Given this list of marker genes Mfn2, Insr, Rbm46, Cited2, Eif4g3, Ptafr, Syce3, Prss37, Unc5c, Ccr6, Lfng, Prdm9, Bnc1 (NCBI Gene Id 12173), Pla2g10, Oxtr, Src, Dhx37, Smurf2, Ube2b, Knl1, Ooep, Cfap69, Cftr, Tmprss12, Meiosin, Inhba, Bax, Fam170b, Adam7, P2ry1 (purinergic receptor P2Y, G-protein coupled 1), Cdc25b, Lhfpl2, Sry, Hdac2, Irgc, Rnase10, Tacr3, Plcb1, Sox9, Zp3, Dazl, Eif2s3y, Tacr1, Ctnnb1, Mapk15, Wt1, Wnt4, Ednrb (NCBI Gene Id 13618), Tac4, Sema3a, Prdm14, Rad51ap1, Cdc25c, Ago2, Plb1, Cib1, Sirt2, Syde1, Cdc25a, Npm2, Npr2, Msx1, Msx2, Cacna1h, Inhbb, Vip, Ythdc2, Piwil2, Camk2b, Defb1, Wnt5a, Vegfa, Iqcf1, Il18, Gja1, Retn, Tac2, Or4m1, Aurka, Apela, Dmrt1, Rnase9 (ribonuclease, RNase A family, 9 (non-active)), Hyal3, Park7, Glra1, Stra8, Ptger4, Runx1, Ccdc87, Zfpm2, Pde5a, Oxt, Meioc, Ar, Tac1, Drd4, C1qbp, Acvr1b, Ankrd31, Abcb1a, Nr5a1, P2ry2, Shh, Defb37, Hdac4, Fbxo5, Spinkl, Cyp51, Ovol1, Tacr2, Igf1r, Pde3a, here is a description of the gene set: Any process that activates or increases the frequency, rate or extent of reproductive process. studied in species Mus musculus Mouse Gene Set: GOBP_POSITIVE_REGULATION_OF_REPRODUCTIVE_PROCESS